The following is a description of a gene set: from publication Bhattacharyya S, Deb J, Patra AK, Thuy Pham DA, Chen W, Vaeth M, Berberich-Siebelt F, Klein-Hessling S, Lamperti ED, Reifenberg K, Jellusova J, Schweizer A, Nitschke L, Leich E, Rosenwald A, Brunner C, Engelmann S, Bommhardt U, Avots A, Müller MR, Kondo E, Serfling E (PMID 21464221) Triggering of B cell receptors (BCR) induces a massive synthesis of NFATc1 in splenic B cells. By inactivating the Nfatc1 gene and re-expressing NFATc1 we show that NFATc1 levels are critical for the survival of splenic B cells upon BCR stimulation. NFATc1 ablation led to decreased BCR-induced Ca++ flux and proliferation of splenic B cells, increased apoptosis and suppressed germinal centre formation and immunoglobulin class switch by T cell-independent antigens. By controlling IL-10 synthesis in B cells, NFATc1 supported the proliferation and IL-2 synthesis of T cells in vitro and appeared to contribute to the mild clinical course of Experimental Autoimmune Encephalomyelitis in mice bearing NFATc1-/- B cells. These data indicate NFATc1 as a key factor controlling B cell function. species: Homo sapiens Human Gene Set: GSE21063_WT_VS_NFATC1_KO_3H_ANTI_IGM_STIM_BCELL_DN Genes down-regulated in B lymphocytes stimulated by anti-IgM for 3h: wildtype versus NFATC1 knockout., and this is the list of marker genes: ASB15, MRPL13, PDLIM4, PRR15, CALHM6, WRN, RCN1, TMEM131L, C4orf17, CNN3, PARP12, SMPDL3B, C6orf89, SERPINB9, MINDY3, PARP9, FPR2, LRRC42, DUSP10, FAF2, WRNIP1, GSTT1, IL15RA, THEMIS2, SLCO3A1 (solute carrier organic anion transporter family member 3A1), ACSL5, TMBIM4, USP25 (ubiquitin specific peptidase 25), ARHGAP31, CDYL, PLBD1, PLEKHG4, AXL, HOPX, CD52 (CD52 molecule), MRM3, PSMB10, RFX5 (regulatory factor X5), CD164, ACOT9, RMDN3, UPP1, TNIP1, FGL2, STX2, MTX2, IRGM, PPARGC1B, IL2RG, INPP5B, UBLCP1, SLC25A12, VASP, SH3BGR, PNP, LPL, HK3, AATF, RBL1, LAP3, PSMB9, TIMM10, ARHGAP15, ZNF800, C8orf33, SSBP2, TRIM21, GPD2, GBP4, ELP5, CCL5, EVA1B, EDN1, TTC9C, KDM5D, LETM1, RASGRP1, NDUFV1 (NADH:ubiquinone oxidoreductase core subunit V1), CCL17, HLA-E, MET, PIK3R6, NAAA, PEX16, TAP2, HIVEP1, ATP11B, PSME1, IFI30, ARL5A, CLINT1, PLXDC2, NXN, IRF1, TYK2, GBP7, MAGOHB, IL18BP, TRIM35, EIF2S1, GCA, INSL6, LY86, CASP3, RNASET2, ALAS1, TAP1, ZNF518B, NDUFA13, ABCC4, STK40, MKRN1, RGS12, NUDT19, SECTM1, ASB13, RAB43, GPC1, DOCK10, C3 (NCBI Gene Id 12266), TFEC, PLAAT3, SAMHD1, PSME2 (proteasome activator subunit 2), CH25H, CD1D, CISH, PTCD2, FAS, C15orf48, IRF8, ITGAX, EXOC3L4, CASP1, HSDL2 (NCBI Gene Id 84263), DGLUCY, TAPBP, TXN, EVL, PPT2, STX3, PCCA, ZNF490, HEBP2, IL18RAP, MAB21L3, TMA16, CD74, SOWAHA, PPP1R17, CXCL9, ASS1, PLAA, CERS6, CLEC7A, IL1RL2, SLAMF8, UBD (ubiquitin D), TMEM154, PSMA5, OOSP2, GNB4, VDR, PRDX5, ARRDC4, C19orf12, SOD2, PILRA, KLRK1, SEMA4A, SDCCAG8, SDHB, DENND1B (NCBI Gene Id 54530), HTR7 (5-hydroxytryptamine receptor 7), ALDH1B1, PARP8, SYNGR2, HLA-DRA, ENDOG, PANX1, PSMB8, CYC1, GBP6, MAPK9, RNF217, ADPRM, CHST15, TNFSF10, ST7, PYGL, PTK2B, REG1B, BATF2, CST7, DRAM1, DNASE1L3, KLHL6, C8orf76, PDCD1LG2, SIAH2 (NCBI Gene Id 6478)